The following is a description of a gene set: studied in species Mus musculus Mouse Gene Set: GOBP_POSITIVE_REGULATION_OF_FATTY_ACID_BETA_OXIDATION Any process that activates or increases the frequency, rate or extent of fatty acid beta-oxidation., and this is the list of marker genes: Cpt1a, Irs2, Twist1, Abcd1, Mtln, Akt2, Obp2a, Plin5, Irs1, Acsl5, Fabp1, Abcd2